The following is a description of a gene set: studied in species Mus musculus The process in which neuroepithelial cells in the ventral neural tube acquire specialized structural and/or functional features of motor neurons. Motor neurons innervate an effector (muscle or glandular) tissue and are responsible for transmission of motor impulses from the brain to the periphery. Differentiation includes the processes involved in commitment of a cell to a specific fate. Mouse Gene Set: GOBP_SPINAL_CORD_MOTOR_NEURON_DIFFERENTIATION, and this is the list of marker genes: Mir92-1, Ighmbp2, Gbx1, Phox2a, Mnx1, Mir19b-1, Ptch1, Pax6, Gli3, Tctn1, Cacna1a, Lhx1os, Ift172, Mir17, Nkx2-2, Lbx1, Mir20a, Abt1, Nkx6-1, Gli2, Olig3, Gdpd5, Mir18, Gigyf2, Hoxd10, Lhx4, Nkx6-2, Isl1, Dicer1, Hoxc10, Lonrf2, Shh, Tbx20, Scyl1, Nfe2l1, Zc4h2, Olig2, Mir19a, Isl2, Lhx3, Dync2h1, Sufu, Scyl3, Cln8, Lmo4